Given this list of marker genes Gimap6, Lclat1, Ric8b, Sfxn1, Gdap2, Gpalpp1, Rorb, Etaa1, Smo (smoothened, frizzled class receptor), Xpo7, Fancl, Nlrp1b, Lypd1, Immt, Cpsf4l, Tceanc, Dmxl1, Gpr63, Upf2, Zfp882, Apol10a, Gpr15lg, Pank1, Gm5934 (predicted gene 5934), Nemp2, Igsf1 (NCBI Gene Id 331408), Impdh1, Mybl2, Ski, Zzz3, Zfp951 (NCBI Gene Id 626391), Mthfd1l, Rp1, Czib, Camk1d, Map1b, Hoxa1, Zbtb33, Cnih3, Tpmt, Arel1, Itk, Col8a1, Brms1, Carnmt1, Pard3b, Bicd1, Fam111a, Mpzl1, Chrd, Jade1, Asph, Clpb, Mcl1, Cant1, Teddm1b (transmembrane epididymal protein 1B), AI182371, Pde1c, Rab43, Skint3, here is a description of the gene set: studied in species Mus musculus Genes predicted to be targets of miRBase v22 microRNA mmu_miR_8106 in miRDB v6.0 with MirTarget v4 prediction scores > 80 (high confidence targets). from publication Chen Y, Wang X (PMID 31504780) Mouse Gene Set: MIR_8106